The following is a description of a gene set: Human Gene Set: KEGG_MEDICUS_REFERENCE_COHESIN_DISSOCIATION_IN_PROPHASE Pathway Definition from KEGG: SGO1+PP2A -| PLK1,AURKB,CDK1 -- STAG+CDCA5 Cohesin dissociation in prophase. Pathway ID: N01485. Pathway type: Reference. Pathway class: nt06512 Chromosome cohesion and segregation. studied in species Homo sapiens, and this is the list of marker genes: PLK1, PPP2R5C, STAG2, PPP2R5B, CDCA5, PPP2CA, PPP2R5D, PPP2R5E, PPP2R5A, AURKB, PPP2CB, PPP2R1B, CDK1, SGO1, STAG1, PPP2R1A